The following is a description of a gene set: Human Gene Set: GOBP_REGULATION_OF_CANONICAL_WNT_SIGNALING_PATHWAY Any process that modulates the rate, frequency, or extent of the Wnt signaling pathway through beta-catenin, the series of molecular signals initiated by binding of a Wnt protein to a frizzled family receptor on the surface of the target cell, followed by propagation of the signal via beta-catenin, and ending with a change in transcription of target genes. species: Homo sapiens, and this is the list of marker genes: RSPO3, TPBGL, MIR212, RUVBL2, MIR1260B, DAAM2, LATS2, SMURF2, TMEM198 (transmembrane protein 198), UBAC2, LGR6, SHH, NKD1, TNKS, CAPRIN2, POU5F1, LGR4, PRKN, SOX4, CTDNEP1, VPS35, SBNO1, GSK3B, APP, DACT3, GPRC5B, PPM1A, VCP, MDK, TMEM170B, APOE, MIR203A, ISL1, GLI3, PTPRO, TBX18, CCNYL3, TMEM64, WNK2, TPBG, SMAD3 (NCBI Gene Id 51521), INVS, MCC, GLI1, NKD2, SFRP5, MIR26A1, CCAR2, PLEKHA4 (NCBI Gene Id 57664), MIR665, DRAXIN, CSNK1A1L, DDX3X, NOG, TLE3, MIR501, MIR199A1, BMAL1, RUVBL1, DDIT3, DKKL1, MIR145, CTNNB1, BTRC, AMER1, MIR498, SDHAF2, GREM1, LRRK1, FGF10, PRICKLE1, NFKB1, FUZ, CDH3, CSNK1G2, CSNK1A1, KPNA1, FZD1, TMEM131L, FZD6, LRP4, WNT3A, USP47, SULF2, KREMEN1, PPP2R3A, WNK1, SNAI2, FGF9, OTULIN, FRMD8, USP8, ZNRF3 (zinc and ring finger 3), DAB2, BAMBI, JUP, TNKS2, NOTCH1, RPS12, AXIN1, FAM53B, MIR19B1, MAPK14, SOX2, SOX17, GSK3A, SHISA6, UBR5, FRZB, RSPO2, TGFB1, CDK14, AMFR, WNT11, IGFBP4, CTNNBIP1, AXIN2 (axin 2), TLE2, ZNF703, BICC1, FGF2, GPC5, CSNK1G1, MAD2L2, MIR29C, NLE1, CTNND2, DKK4, SRC, YAP1, G3BP1, LMBR1L (limb development membrane protein 1 like), GID8, PTPRU, NPPA, STK4, SFRP2, BMP2, ADNP, MIR1-1, AMER3, CTHRC1, ZEB2, GNAQ, DKK3, DAB2IP, RNF220, NPHP3, SCEL, NPHP4, IGFBP1, MIR346, WWTR1, RSPO1, GPC3, LRRK2, WNT5B, HDAC1, NRARP, FRAT1, BIRC8, FERMT1, LYPD6, MIR29B1, TMEM9, FOLR1, SOST, SFRP4, PIN1, ILK, JADE1, COL1A1, RBPJ, LIMD1, SOX10 (SRY-box transcription factor 10), TBL1X, WNT10B, RNF14, ATP6AP2, PPM1N, TRPM4 (transient receptor potential cation channel subfamily M member 4), RBMS3, WLS (Wnt ligand secretion mediator), APC2, WNT5A, LGR5, CBY1, TMEM196, TCF7L2, NHERF1, PSEN1, SPIN4, PRDM15, TMEM88, TMEM88B, ASPM (NCBI Gene Id 93990), TLE1, TLE4 (NCBI Gene Id 7091), AMER2, STK11, FRMD8P1, TBL1XR1, IGFBP6, CCNYL2, CCNYL1, TLE7, KANK1, SOX9, FZD9, CDH2, MIR183, SOSTDC1 (NCBI Gene Id 25928), MLLT3, JRK, SIAH2, OTUD5, FOXO3, APC, EGF, PPP2CA, TLE5, PPP1CA, NKX2-5, ANKRD6 (ankyrin repeat domain 6), DAPK3, CCNY, HHEX, DKK2, SHISA3, MKS1, RSPO4, DLX5, ADGRA2, EGR1, SOX13, TTC21B, LATS1, USP34, SEMA5A, FZD7, PFDN5, SFRP1, EGFR, CSNK1G3, CSNK1E, NOTUM, CSNK1D (NCBI Gene Id 1453), HECW1, RECK (NCBI Gene Id 8434), XIAP (NCBI Gene Id 8257), DKK1, PTK7, CCDC88C, STK3, SCYL2, EMD, UBE2B, FOXO1, TLE6, RBX1, ZBED3, CHD8, LZTS2, IGFBP2, MESP1, CAV1, PPM1B, RNF146, SMAD4 (NCBI Gene Id 4089), FGFR2, EDA, CCNYL1B, DACT1, CYLD, GSKIP, IFT20